The following is a description of a gene set: On the basis of epidemiological studies, infection was suggested to play a role in the etiology of human cancer. While for some cancers such a role was indeed demonstrated, there is no direct biological support for the role of viral pathogens in the pathogenesis of childhood leukemia. Using a novel bioinformatic tool that alternates between clustering and standard statistical methods of analysis, we performed a 'double-blind' search of published gene expression data of subjects with different childhood acute lymphoblastic leukemia (ALL) subtypes, looking for unanticipated partitions of patients, induced by unexpected groups of genes with correlated expression. We discovered a group of about genes, related to the interferon response pathway, whose expression levels divide the ALL samples into two subgroups; high in 50, low in 285 patients. Leukemic subclasses prevalent in early childhood (the age most susceptible to infection) are over-represented in the high-expression subgroup. Similar partitions, induced by the same genes, were found also in breast and ovarian cancer but not in lung cancer, prostate cancer and lymphoma. About 40% of breast cancer samples expressed the 'interferon-related' signature. It is of interest that several studies demonstrated mouse mammary tumor virus-like sequences in about 40% of breast cancer samples. Our discovery of an unanticipated strong signature of an interferon-induced pathway provides molecular support for a role for either inflammation or viral infection in the pathogenesis of childhood leukemia as well as breast and ovarian cancer. species: Homo sapiens A gene expression signature found in a subset of cancer patients suggestive of a deregulated immune or inflammatory response. from publication Einav U, Tabach Y, Getz G, Yitzhaky A, Ozbek U, Amariglio N, Izraeli S, Rechavi G, Domany E (PMID 16007187) Human Gene Set: EINAV_INTERFERON_SIGNATURE_IN_CANCER, and this is the list of marker genes: BRD3, BST2, RXRA, ISG15, IFI6, OAS2, IFI30, IFI35 (interferon induced protein 35), SP100, IRF9, LY6E, ERG (NCBI Gene Id 2078), SP110, IFI44, APOBEC3G, STAT1, TGIF1, OAS1, IFIT3, ADAR, CMTR1, IFIT1, MORC3, MX1, UBE2L6, EIF2AK2, IFI44L